Given this list of marker genes ESR1, TGFB1, AREG, MED1, TFAP2C, WNT5A, here is a description of the gene set: Human Gene Set: GOBP_BRANCH_ELONGATION_INVOLVED_IN_MAMMARY_GLAND_DUCT_BRANCHING species: Homo sapiens The developmental growth process in which a branch of a mammary gland duct elongates.